Given this list of marker genes TRPC3, PPP3CA, MIR214 (NCBI Gene Id 406996), MIR20A, MIR199A1, APLNR, FOXO3, MIR34B, MYMK, MYOG (NCBI Gene Id 4656), MIR208A, MIR17, MIR34C, MIR17HG, here is a description of the gene set: Any process that activates or increases the frequency, rate or extent of muscle adaptation. studied in species Homo sapiens Human Gene Set: GOBP_POSITIVE_REGULATION_OF_MUSCLE_ADAPTATION